Given this list of marker genes Gfra2, Gfral, Gfra4, Mmp14, Nrtn, Gdf15, Gfra1, Gfra3, Ret, Artn, Sulf2, Gdnf, Gata3, Pspn, Sulf1, here is a description of the gene set: The series of molecular signals initiated by a ligand binding to a glial cell-derived neurotrophic factor receptor. species: Mus musculus Mouse Gene Set: GOBP_GLIAL_CELL_DERIVED_NEUROTROPHIC_FACTOR_RECEPTOR_SIGNALING_PATHWAY